Given this list of marker genes Plbd1, Pla2g4d, Pla2g4f, here is a description of the gene set: electronically inferred by orthology from the curated human pathway This event has been computationally inferred from an event that has been demonstrated in another species.<p>The inference is based on the homology mapping from PANTHER. Briefly, reactions for which all involved PhysicalEntities (in input, output and catalyst) have a mapped orthologue/paralogue (for complexes at least 75% of components must have a mapping) are inferred to the other species. part of: Glycerophospholipid biosynthesis studied in species Mus musculus Reactome Pathway: Hydrolysis of LPC